Given this list of marker genes PRKAR2A, CHP1, TESC, PRKAG2, GMFB, CDKN2C, SPRY2, SH3BP5, AKT1, LILRB4, SPRED2, INKA1, NPM1, WARS1, CASP3, PKIB, KAT2B, CDKN2B, RHOH, QARS1 (glutaminyl-tRNA synthetase 1), TAOK3, INKA2, HTRA2, CDKN1A, SMCR8, HYAL2, TRIB2, PRKCH, MAPK8IP1, PKIA, PTPRC, GSTP1, CDKN2A, RPTOR, DEPTOR, DUSP22, TESK1, CIB1, GMFG, SFN, CDKN1C, DUSP3, SNCA, TRIB1, SMO, DUS2, ANKRD42, SPRED1, ATAD3A, YWHAG, PAK1IP1, NCK1, PREX1, IBTK (inhibitor of Bruton tyrosine kinase), PPP5C, DNAJC3 (DnaJ heat shock protein family (Hsp40) member C3), PRKAR1A, PRKRIP1, HSPA5, CAMK2N2, SOCS3, SH3BP5L, YWHAB, INCA1, MBIP, CEP43, CIT, TRIB3, PRKAR2B (protein kinase cAMP-dependent type II regulatory subunit beta), HEXIM2 (NCBI Gene Id 124790), ITPRIP, AHSG (NCBI Gene Id 780898), PPEF2, SPRY4, DUSP19, PRKAR1B, RACK1, PPP2R5A, PARVA, GSKIP, GCKR, CAV1, PPP1R1B, LRP6, SOCS1, CAMK2N1, MACROH2A1, HSPB1, PREX2, ANKLE2, AKT1S1, PKIG, PYDC1, CDKN2D, CDKN1B, HEXIM1, here is a description of the gene set: studied in species Homo sapiens Human Gene Set: GOMF_KINASE_INHIBITOR_ACTIVITY Binds to and stops, prevents or reduces the activity of a kinase.